Given this list of marker genes Agtr1b, Nrp1, Trim38, Exoc7, Axl, Cldn1, Npc1, Vps16, Cd209e (CD209e antigen), Grk2, Uvrag, Lgals1, Hmgb1, Rnasek, Cd209d, Cd4, Fuca2, Tnfrsf14, Ctsb, Cldn9 (NCBI Gene Id 56863), Cd300lf, Trim12c, Jpt2 (Jupiter microtubule associated homolog 2), Clec4g, Tmprss11d, Ch25h, P4hb, Trim11, Cd209c, Trim30c, Cav1, Phb1, Nectin4, Itgb3, Nectin2, Tmprss2, Slc20a2, Hyal2, Itgav, Tyro3, Gas6, Cd81, Hs3st5, Siglec1, Spint1, Avpr1b, Gpr15, Nectin3, Trim12a (tripartite motif-containing 12A), Pikfyve, Bsg, Trim5, Smpd1, Slamf1, Cd74, Tmprss11a, Cd300ld, Myh9, Clec5a, Trim25, Ace2, Cav2, Ceacam1, Xpr1, Tpcn2, Siva1, Trim30b, Vamp8, Slc3a2, Vps18, Zfp639, Tmprss4, Nectin1, Avp, Tmprss11e, Trim30d, Cldn6, Slc7a1, Dpp4, Furin, Naip5, Agtr1a, Trim62, Trim30a, Insr, AU040320, Exoc2, Tpcn1, Dag1, Eps15, Ilf3, here is a description of the gene set: Entry of a symbiont into the body, tissues, or cells of a host organism as part of the symbiont life cycle. The host is defined as the larger of the organisms involved in a symbiotic interaction. Mouse Gene Set: GOBP_SYMBIONT_ENTRY_INTO_HOST studied in species Mus musculus